The following is a description of a gene set: Mtb enhances its chances for being taken up by a phagocyte by blocking adaptive immune responses, as well as other innate immune system responses. Components of the bacterial cell wall also specifically promote phagocytosis via both the opsonic pathway and the presentation of adhesins. part of: Infection with Mycobacterium tuberculosis Reactome Pathway: Modulation by Mtb of host immune system studied in species Homo sapiens, and this is the list of marker genes: UBA52, UBB, MRC1, ptpA, esxA, aldR, UBC, pstS1, B2M (beta-2-microglobulin), RPS27A, TLR2